Given this list of marker genes MCPH1, PRKAR1B, KCNMA1, SGK1, PRSS35, GRK4, CNTNAP3, PPP1R3B, NDST2, TMEM116, IL13RA1, FAM43A, GNA14, GAL3ST1, NPAS2, TSPAN8, ITGA6, MAGT1, UTS2, GLP1R, ZNF175, ST3GAL6, COL8A1, EPHA5, CAP2, IL9R, CFDP1, SPART-AS1, LMAN1, ITGBL1, NCF4, SNTB2, TFPI, NAV2, IQCA1, ST3GAL1, MMP1, OR12D2, ATP9A, TMSB15A, UBXN10, MS4A1, MYEF2, USP34, ADCY7, IFI6, SORL1, GJA1, AP3B2, FLI1, ANXA10, PYROXD1, CCN2, CMTR2, SERPINE1, SLC12A2, HAS3, C1D, EMP1, CXCL5, MAP3K8, ARHGAP5 (NCBI Gene Id 394), PCLO, KLF9, MGLL, GULP1, TNRC6B, BBOF1, CD164, FAR2 (NCBI Gene Id 55711), RBMS3, KIAA1549L, PLAAT2, UST, DNER, CACTIN, CCDC50, MAGEC2, ACAD8, FHL1, NOL3 (NCBI Gene Id 8996), GBA2, DPF3 (NCBI Gene Id 8110), YPEL5, HPGD, ELOVL2, MYRFL, CPE, RAB3B, SLC4A8, GALNS, MYO1D, ZFX, PIERCE1, CSGALNACT2, PRR16, NNMT, NEBL, UHRF2, H4C8, MAP4K3, AOX1, MAB21L2, OSR1, VAMP4, NEK3 (NCBI Gene Id 4752), VPS13C (vacuolar protein sorting 13 homolog C), SCN2A, AVL9, KLF3, ZNF766, NRP1, HEMGN, CP, MEF2D, OR7D2, LOXL4, SPOCK1, CCM2L, TRIM2, RNASE4, NEGR1, CNIH3, IGFBP3, RNF213-AS1, DLX2, C1S, KLF2, SLAMF6, DNAJB8-AS1, SPARC, PCK1, ZEB1, NIP7, PLA2G12B, SPRY4, FOXA2, ABI3BP, COMMD10, SRRM2, RNPC3, COL3A1, ANO1, NMNAT1, TTC28, PRIM2, CRISPLD1, WWTR1, EDIL3, LINC00550, RBP4, MSX2, SNORC, NT5E, ARK2N (NCBI Gene Id 147339), TNFAIP6, ABCA5, IGFBP5, COL1A1, CCL20, IFIT2, ABRAXAS2, TMTC1, CYP19A1, FABP4, ACKR2, GPC6, ARHGEF3, SUSD4, VTI1A, ANOS1, SLC2A10, RNF144B, TNFRSF6B, HSD17B2, MYLK (myosin light chain kinase), NIPSNAP3A, APBB2 (NCBI Gene Id 323), HAS2, KRTAP4-12, CD59, MYO16, LPAR6, ZNF37BP, LY9, RBMX, DSEL, RRAGD, GABARAPL2, ST6GALNAC4, EDN1, NTN4, APP, COA3, SAMD4A, SYT6, IRX5, ELMO1, SIGLEC5, SERPINB3, ZNF76, AKAP13, ANTXR2, SSPN, HOXC8, ID2, ZNF567, TPM3, KAAG1, TMEM45A, TYRP1, PRB3, TACR1, SCARB1, AHCTF1, LMCD1, SHISA3, BCL2A1, HLF, IL6R, TNP2, EGFR, IFIT3, C6orf89, ATP8B1, MATN3, DOCK4, TSC1, DYNLT2, here is a description of the gene set: from publication Kondo Y, Shen L, Cheng AS, Ahmed S, Boumber Y, Charo C, Yamochi T, Urano T, Furukawa K, Kwabi-Addo B, Gold DL, Sekido Y, Huang TH, Issa JP (PMID 18488029) Genes up-regulated in PC3 cells (prostate cancer) after EZH2 knockdown by RNAi. studied in species Homo sapiens Epigenetic silencing in cancer cells is mediated by at least two distinct histone modifications, polycomb-based histone H3 lysine 27 trimethylation (H3K27triM) and H3K9 dimethylation. The relationship between DNA hypermethylation and these histone modifications is not completely understood. Using chromatin immunoprecipitation microarrays (ChIP-chip) in prostate cancer cells compared to normal prostate, we found that up to 5% of promoters (16% CpG islands and 84% non-CpG islands) were enriched with H3K27triM. These genes were silenced specifically in prostate cancer, and those CpG islands affected showed low levels of DNA methylation. Downregulation of the EZH2 histone methyltransferase restored expression of the H3K27triM target genes alone or in synergy with histone deacetylase inhibition, without affecting promoter DNA methylation, and with no effect on the expression of genes silenced by DNA hypermethylation. These data establish EZH2-mediated H3K27triM as a mechanism of tumor-suppressor gene silencing in cancer that is potentially independent of promoter DNA methylation. Human Gene Set: KONDO_EZH2_TARGETS